Given this list of marker genes ANAPC7, ANAPC4, CDC26, UBE2C, CDK1, ANAPC10, PLK1, CDC27, UBE2S, ANAPC11, ANAPC16, UBE2E1, ANAPC15, UBE2D1, ANAPC1, CDC23, ANAPC2, CCNB1 (NCBI Gene Id 891), CDC16, ANAPC5, here is a description of the gene set: Reactome Pathway: Phosphorylation of the APC/C part of: Activation of APC/C and APC/C:Cdc20 mediated degradation of mitotic proteins species: Homo sapiens Phosphorylation of APC subunits is required for Cdc20 mediated activation by of the APC/C at the metaphase anaphase transition. While the kinases responsible for phosphorylation in vivo have not been determined with certainty, both Plk1 and Cyclin B:Cdc2 have been implicated in this process.